The following is a description of a gene set: Marker genes curated from the annotated cluster as represented in the Descartes Human Gene Expression During Development database. Human Gene Set: DESCARTES_MAIN_FETAL_ISLET_ENDOCRINE_CELLS studied in species Homo sapiens The gene expression program underlying the specification of human cell types is of fundamental interest. The study authors generated human cell atlases of gene expression and chromatin accessibility in fetal tissues. For gene expression, the study authors applied three-level combinatorial indexing to >110 samples representing 15 organs, ultimately profiling ~4 million single cells. The study authors leveraged the literature and other atlases to identify and annotate hundreds of cell types and subtypes, both within and across tissues. Our analyses focused on organ-specific specializations of broadly distributed cell types (such as blood, endothelial, and epithelial), sites of fetal erythropoiesis (which notably included the adrenal gland), and integration with mouse developmental atlases (such as conserved specification of blood cells). These data represent a rich resource for the exploration of in vivo human gene expression in diverse tissues and cell types. from publication Cao J, O'Day DR, Pliner HA, Kingsley PD, Deng M, Daza RM, Zager MA, Aldinger KA, Blecher-Gonen R, Zhang F, Spielmann M, Palis J, Doherty D, Steemers FJ, Glass IA, Trapnell C, Shendure J (PMID 33184181), and this is the list of marker genes: FEV, ENSG00000263571, CASR, ERO1B (endoplasmic reticulum oxidoreductase 1 beta), TBCC, CAMK2N1, FAM131C, NKX2-2, NKX6-1, SLC30A8, IAPP, STX1A (syntaxin 1A), ACVR1C, RAB26, SNX10-AS1, ENSG00000257228, MAFA, RAB3B, ACLY, SSTR5-AS1, NEUROG3, SSTR5, PTPRN, GNAS, CACFD1, CCDC188, PABPN1L, TTR, ENSG00000224090, RASA4CP, PLUT, SCGN, CALY, ECEL1, LINC01370, ABCC8, HPCA, HADH, BTBD17, SUV39H2-DT, INS, G6PC2, SYNDIG1L, SST, MAFB, PCSK1N, CABP7, ARX, LINC02106, EGR4, PAX4, ASB9, SF3B5 (splicing factor 3b subunit 5), KCNJ11, VWA5B2, C1orf127, SYNGR4, CNIH2, RTL5, KCNK16, NOL4L-DT, C22orf42, GCG, NSMF, LINC02131, HSPA1A, GCK (glucokinase), PCSK1, PPY, PLD3 (phospholipase D family member 3)